Given this list of marker genes Gabra2, Cit, Shisa7, Gabrq, Phf24, Gabbr2 (gamma-aminobutyric acid type B receptor subunit 2), Plcl1, Gabra5, Gnai2, Gabrg1, Atp1a3, Gabra4, Gabrr2, Cacna1a, Pianp, Gabrb1, Gabre (gamma-aminobutyric acid (GABA) A receptor, subunit epsilon), Gpr156, Atf4, Htr1a, Gabra3, Gabra6, Gabrd, Cacnb4, Gabrb2, Gabra1, Gabbr1, Plcl2, Htr4, Gabrg2, Gabrb3, Gabrg3, Bdnf, Slc12a2, here is a description of the gene set: species: Mus musculus Mouse Gene Set: GOBP_GAMMA_AMINOBUTYRIC_ACID_SIGNALING_PATHWAY The series of molecular signals generated by the binding of gamma-aminobutyric acid (GABA, 4-aminobutyrate), an amino acid which acts as a neurotransmitter in some organisms, to its receptor on the surface of a target cell.